Given this list of marker genes FBXO32, NKX3-1, KPNA1, STAM2, CCDC186, CREBRF, MAGI1, ROCK1, NPTX1, PTPN9, C8orf44-SGK3, AGMAT, MEF2A, ABI1, CAV2, FZD4, SLC20A2, PPP3R1, MEIS2, EIF4G2, APOOL (apolipoprotein O like), SPARCL1, FAT4, RASEF (RAS and EF-hand domain containing), SLMAP, STRN3, IL15, SS18 (NCBI Gene Id 6760), ONECUT2, NR2F2, EPHA5, KCTD10, UBE2D1, CBX4, FNDC3A, PMPCB, MSI2, BMPR1A, SLC66A3, NFE2L2, SMARCA4, MRTFB, FOS, USP42, USP9X, RUNX1 (NCBI Gene Id 861), STARD8, ZNF181 (zinc finger protein 181), IDH2, AFG2B, PLEKHG1, ZFHX4, BTAF1 (NCBI Gene Id 9044), EPN2, ANKS1A, MAPK9, ARHGAP18, CNTN3, GPRASP3, ETS1, TRIO, CNOT4, SUCLG2, MCF2L, HNRNPF, APP, GRIK2, ZNF827, CAMTA2, SEMA6D, DR1, ANGPTL3, MORC3, ZFP36L2, TAB3, MEGF9, NCF2, QSER1, ST3GAL6, RNF111, BBX, SLC12A2, NAA15, MAP3K9, FBN2, TTN, CTTNBP2 (cortactin binding protein 2), TGIF2, NID2, ZCCHC2, PRDM16, FZD6, NYAP2, MTX3, VLDLR, ITPR1, IL7, TBC1D9B, APLP2, SEPTIN2, CXCL12, FBXW11, APPBP2, TRIM44, UCK2, EMP1 (NCBI Gene Id 2012), BICC1, CEP68, LDLRAD4, GALNT1, SGPP1, OTOGL, SP4, ANKRD28, GLCCI1, PDE3B, FBXL3, PAFAH1B1, BNC2, ZDHHC21, EPB41L2, MED6, KIDINS220, ZNF571, CALCRL, SON, FSBP, ZNF367, BMPR1B, STC1, MFSD6, GRM5, PURA, SLIT3, RGMA, SNTB2, ADRA1A, SOCS7, FMN2, MMGT1, ST18, POMP, ETNK1, FLRT3, EZH2 (NCBI Gene Id 392834), MED13, TMSB4Y, SYNCRIP (synaptotagmin binding cytoplasmic RNA interacting protein), TSHZ3, FEM1C, PRKD3, DDIAS, UBE2D2, NSMCE3, C2orf49, GK5, RIGI, SLC25A3, MYOCD, UBE2G1, SCN8A, ADAMTSL3, NACC2, GOLGA7, SUV39H2, DYRK2, MOB4 (MOB family member 4, phocein), PRICKLE1, GATA3, NOS1, HIPK3, CCNG2, TMTC3, HAT1, EXOC5, ACER3, SHPRH, ZNF597, ZFAND4, BCLAF3 (BCLAF1 and THRAP3 family member 3), FUCA2, MAP7D1, UTS2B (urotensin 2B), GNG12, NRK, TBX18, NEK6 (NCBI Gene Id 58167), USP38, ALS2, FAHD2B, SEC24A (NCBI Gene Id 10802), SLC44A5, LRCH2, NCKAP1, NLK (NCBI Gene Id 51701), SLC4A10, CASTOR2, SH2B3, DLG5, PI15, SLC15A5, AFDN, SNX13, RASSF8, TFB1M, LRP12, SLC1A1, CAV3, FAM98A, FLT1, PCDH20, CEP170, TRIB1, MGAT4A, PRKAA1, POU4F2, ZNF260, CWC27, PEDS1-UBE2V1, CDH5, AKAP11, AEBP2, TNPO1, KITLG, FAM76B, VANGL1, FAM174A, KLRC4, TBL1XR1, ZC3H11A, KIF3A, ARHGAP42, TOGARAM1, CCDC88A, PNRC1, WEE1 (WEE1 G2 checkpoint kinase), ARID2, MED4 (mediator complex subunit 4), MARK1, IGIP, XIRP2, ERO1A, THAP1, FBN1, ZFX, BACH2, ZBTB34, CACNA2D1, PIKFYVE, ATAD2B, ANTXR2, BRPF1, PPP2R2A, TJP1, CAAP1, DST, GNA13, CDV3, SORCS3, MYCN, LIFR, SLC30A7, CEP55, SLC7A11, GBE1, ERBB4, GPR176, RIN2, SACM1L, HYCC2, LIMCH1, EBF1, HDHD2, RASGRF1, SLITRK4, ZC3H6, BAZ2B, STIL, ACBD5, MYBL1, SOBP, SLC25A36, FMR1, CCNT2 (NCBI Gene Id 905), ZBTB21, RARB, ATXN1, TP53BP2, GABRA1, ADAMTS17, ZPBP2, MTMR9, ARPP21, SGK3 (NCBI Gene Id 23678), ARID1A, SCN1A, NPY1R, AP1G1, ZNF570, ZBTB18, RAP2C, CDYL, KCNMB2, RASD2, GDF10, ZNF704, MAPK6 (mitogen-activated protein kinase 6), ATP2B1, ALDH1L2, SEMA6A, E2F8, AFAP1, ACSL4, HDHD5, CGGBP1, ALDH1A3, ZEB1, KL, TMF1, GPD2, ZNF207, BMAL2, SREK1, LRRC1, XYLT1, CADM2, MBNL1, WIF1, KIAA1217, BBC3, PTHLH (parathyroid hormone like hormone), TEK, SMAD9, LPGAT1, MYO1E, GCNT1, RGS17, MAP3K13, BEGAIN, ABCA1, SINHCAF, CDKN2AIP, MED12L, HEY2, ADAMTS3, IQSEC1 (IQ motif and Sec7 domain ArfGEF 1), UBE2V1, MYEF2, RAD54B, DIMT1, ATP5MC2, MSX1, OTUD4, PDS5B, CXCL11, SETD5, TGFBR1, CACNA1D, WWTR1, ATP2B2, HVCN1, DTWD1, PRRX1, INSYN2A, SH3TC2, TFAP4, SLC45A3, SHISA6, ELAVL2, ABHD17B, NR1D2, ZNF800, RBMXL1 (RBMX like 1), REL, FN1, MAP3K2, SPOPL, MAFK, PBX3, ZC2HC1A, C19orf73, GRID2, LSM14A, FAM199X, PPP1R16B, MAP3K8, BCL2L11, GRIK4, FST, CCDC85A, BICD2, FGD6, ARHGAP5, AXIN2, GRIK3, RFX3, IMPACT, NRP2, EIF5A2, PANK1, THAP5, WDR3, IMPA1, SLC35A3, KPNA2, PDE4D, ACBD3, CPEB2, TET2, NT5DC1, MAML3, EXPH5, SELENOT, NIPA2, FAM222B, SNAP91, CRBN, NEK7, ZC3H12A, HSPE1-MOB4, PREX2, S1PR3, MXRA5, MTOR, SCN2A, UBR3, UBE2A, ACYP2, MED14, NETO2, SUCLA2, SPIRE1, PLA2G4A, IPO8, LCOR, KCTD4, SSX2IP, TBX1, ARHGAP26, ANO1, TSPAN12, PCDH18, MAP3K4, RORA, PTEN, IFFO2 (intermediate filament family orphan 2), GRHL3, YWHAG (NCBI Gene Id 96443), PTCH1, GJA1, PCDH7, EFEMP1, ZC3H12C, BCL9, SLAIN2, LRAT, GXYLT1, NDST3, HTRA3, DIXDC1, PRKRA, ERBIN, PPTC7, LRPPRC, HNRNPU, KCNJ6, GABPB1, EXOC1, ACBD7, CDK8, BRD10, STAG1, TNFSF11, PTPN4, MINAR1, ATP1B1, SALL1, TRAPPC8, PDE8A (NCBI Gene Id 5151), CLDN8, NF1, SMARCA1, ABHD17C (abhydrolase domain containing 17C, depalmitoylase), KIF2A, DCBLD2, ZNF148, PURB, NAV3, PPP2R2D, CACNB2, POLR3G, RGL1, INO80D, ADAMTS5, VKORC1L1, here is a description of the gene set: species: Homo sapiens Genes predicted to be targets of miRBase v22 microRNA hsa-miR-144-3p in miRDB v6.0 with MirTarget v4 prediction scores > 80 (high confidence targets). from publication Chen Y, Wang X (PMID 31504780) Human Gene Set: MIR144_3P